The following is a description of a gene set: Dendritic cells (DCs) process and present self and foreign antigens to induce tolerance or immunity. In vitro models suggest that induction of immunity is controlled by regulating the presentation of antigen, but little is known about how DCs control antigen presentation in vivo. To examine antigen processing and presentation in vivo we specifically targeted antigens to the two major subsets of DCs using chimeric monoclonal antibodies. Unlike CD8+ DCs that express the cell surface protein CD205, CD8- DCs, which are positive for the 33D1 antigen, are specialized for presentation on MHC class II. This difference in antigen processing is intrinsic to the DC subsets and associated with increased expression of proteins associated with MHC processing. Genes down-regulated in cells from Flt3L Melanom injected mice: splenic DEC205+ dendritic cells versus CD4 T cells. Human Gene Set: GSE6259_FLT3L_INDUCED_DEC205_POS_DC_VS_CD4_TCELL_DN species: Homo sapiens from publication Dudziak D, Kamphorst AO, Heidkamp GF, Buchholz VR, Trumpfheller C, Yamazaki S, Cheong C, Liu K, Lee HW, Park CG, Steinman RM, Nussenzweig MC (PMID 17204652), and this is the list of marker genes: GPS1, DNALI1, NPTX2, ARRDC5, MST1R, HS6ST3, NAGS, GARIN3, PUDP, PHLDA3, LGI3, COX6A2, CPLX3, AMOTL1, PYM1, BEST3, ME1, TRIM75, ICA1L, MOB3B, TRIP6, GNG3, CDA, TIGD5 (NCBI Gene Id 84948), CATSPERB, TRPT1, PTN, RSPO4, DCSTAMP, SLC26A7, LAMB3, TCAM1P, CDH4, EVC2, GUCY1A2, MNX1, EPAS1, CSPG4, GOLM2, NKD2, REEP1, DRD2, SPIN4, SAA3P, MEOX1, NANOS2, SERPINA7, HECW2, TMEM74, ADGRA3, PNMA8B, RP1L1, ZIC5, BHLHA15, ARHGEF17, SUPT20HL1, CENPV, JPH1, CHCHD6, LRP4, AIFM3, TEAD1, FNDC8, FMO5, PPP1R3C, PPL, JAZF1, CLDN23, DIO3, CLEC2L, SCRT1, GABRA3, PAX7, C1D, ELN, CADM2 (NCBI Gene Id 253559), GPRIN2, UTS2, ACP4, SDK2, MAGEL2, H2AB1, ONECUT1, OSCAR, IRX6, GML, COLEC11, PAPPA, GPR3, DAW1, MIR7-2, RAB3D, NFASC, KIF7, SIX5, FGFR3, BIK, SFT2D3, LMX1B, FAM222A, DMXL2, PLAC9, LMX1A, NRBP2, AGR2, KRT75, RTL3, APC2 (NCBI Gene Id 10297), TMEM143, GUCA1B, NOG, CPN2, UPK1A, PGBD1, GMPR (NCBI Gene Id 2766), TOX2, RBM11, STXBP1, COL6A6, SLC6A15, WNT8A, FKBP6, MS4A14, LRFN3, PDGFRB, OVOL1, TMPRSS4, GRK1, SYNM, SYT5 (synaptotagmin 5), GUCY1B2, MYH7B